The following is a description of a gene set: species: Homo sapiens This pathway depicts the binding of an experimentally-verified range of ligands to FGFR3b. While binding affinities may vary considerably within this set, the ligands listed have been established to bring about receptor activation at their reported physiological concentrations. Reactome Pathway: FGFR3b ligand binding and activation part of: FGFR3 ligand binding and activation, and this is the list of marker genes: FGF18, FGF1, FGF20, FGFR3 (fibroblast growth factor receptor 3), FGF9, FGF8, FGF17